Given this list of marker genes VEZF1, POU2F1, HEXA, KDELR2, NME4, MAP3K5, TDRD3, AMPD2, HLA-E, MSH3, CGGBP1, MDFIC, ANKS1A, APRT, IDH3G (NCBI Gene Id 3421), PFKP, CLEC2B, FAM98A, CCT6A, DCAF8, PDE3B, ST14, BUB1B, COIL, ARSA, KLF4, SHC1, ZMIZ1, RABGGTB, USF2, SMC3 (NCBI Gene Id 9126), SGMS1, WDFY3, SNX2, ALG8, F2, RBMX, SLC38A10, FYN, RNF6, TRAPPC8, ZBTB1, BTG2, RXRA, EEF1B2, FASTK, WIPI2, USP15, ALDH3A2, RPL22, ALDH5A1, PRKY, TXNL1, MRS2, CPVL, VSIG4, LPL, RPS6KA1, SREK1, MUC6, MIA2, SLC35A3, HELZ, SPINK4, SYT17, UTP14C, DAB2, TMEM131, ACTR2, PSMD3, FCAR, BLOC1S1, ERCC1, SLCO2B1, PTDSS1, EIF4EBP1, ASF1A, MED12, SLC25A12, RNF8, RLIG1, DPYD, STX5, DRAP1, AASDHPPT, CDH2, FARSA, SVIL, TUFM, CD1B (CD1b molecule), SEC14L1, APOC1, DNAJC16, IQSEC2, MRC2, PGRMC2, FLI1, URI1, XYLT1, GRHPR, KAT2A, ASAP2, CPNE3, EIF2B5, SLC7A8, P2RY11, TACC1, SPN, PHF8, BLMH, TSC2, CNOT3, ATP2B1, BLCAP, GNRH2 (gonadotropin releasing hormone 2), CDC6, SPICE1, IFNA16, ZC3H15, AMHR2, TMX4, DGCR2, KPNA5 (karyopherin subunit alpha 5), VAV1, RPS10, ARHGAP4, RCBTB2, GART, AP2A2 (NCBI Gene Id 25955), TET3 (NCBI Gene Id 23298), GOLGA8A, GSTP1, NDUFS6, KYAT1, LAIR2, DNASE2, B3GNT2, PRPF40A, FGL2, VGLL4, CD14, MEF2A, RNF187, MNDA, CD1D, ACP5, GPX3, UBA7, PPP6R1, TRAF3IP1, KDELR3, HLA-DRB4 (major histocompatibility complex, class II, DR beta 4), SMPD1, ALDH1A1, CD1E, P2RY14, RPS14, TASOR, PSMD8, TREX1, TBC1D2B, ARF6, GNPAT, AP1S2, ZZZ3, MYCBP2, ST3GAL5 (NCBI Gene Id 8869), CREB3L2, DLEC1, INPP5D, UBXN1, CMAHP, RPS4Y1, MEGF9, SELENOP, SGCG, SYNE1, SEPTIN9, TMEM59, TLE5, CBX7 (chromobox 7), ADORA3, LY96, UBAC1, PREPL, NASP, TXNIP, TKT, ROR2, PCNA, HCFC1, NCAPD2, RAB5C, NDUFV1, NUP210, ERP29, DDX28, PECAM1, HPCAL1, here is a description of the gene set: Monocyte-derived dendritic cells (DC) and macrophages (MΦ) generated in vitro from the same individual blood donors were exposed to five different pathogens, and gene expression profiles were assessed by microarray analysis. Responses to Mycobacterium tuberculosis and to phylogenetically distinct protozoan (Leishmania major, L. donovani, Toxoplasma gondii) and helminth (Brugia malayi) parasites were examined, each of which produces chronic infections in humans yet vary considerably in the nature of the immune responses they trigger. studied in species Homo sapiens from publication Chaussabel D, Semnani RT, McDowell MA, Sacks D, Sher A, Nutman TB (PMID 12663451) Genes down-regulated in comparison of dendritic cells (DC) exposed to L. donovani versus DCs exposed to 50 worm/well B. malayi. Human Gene Set: GSE360_L_DONOVANI_VS_B_MALAYI_HIGH_DOSE_DC_DN